Given this list of marker genes NRGN, KIAA0753, NRCAM, SERPINI1, SPP1, HOMER2, MAPT, P2RX3, here is a description of the gene set: Cluster 8: genes showing sustained pattern of down-regulation after knockdown of OPN by RNAi in the NIH3T3 cells (fibroblasts) transformed by activated HRAS. species: Mus musculus Activated forms of Ras family members are prevalent in many cancers where Ras mutants transduce signals essential for transformation, angiogenesis, invasion and metastasis. As a cancer progression model, we used NIH3T3 cells to explore the mechanism of Ras-induced tumorigenesis. Ras family mutants H-RasV12 and Rit79L strongly induced foci formation, while Rho family mutants RhoA-QL, Rac1-QL and Cdc42-QL were less effective. A comparison of downstream transcriptional targets of Ras and Rho family members using a 26 383 element cDNA microarray revealed that the osteopontin (OPN) gene exhibited the best correlation between magnitude of gene expression change and level of foci formation (r=0.96, P<0.001). In association with H-RasV12- and Rit79L-mediated transformation, foci secreted OPN protein and upregulated the OPN receptor CD44, suggesting the novel initiation of an aberrant OPN-CD44-Rac autocrine pathway. In support of this were the following observations. First, RGD-deficient OPN protein-binding activity was present in H-RasV12-transformed cells but not in control cells, and binding activity was inhibited by the CD44 blocking antibody. Second, foci formation, cell invasion and Rac activity were induced by H-RasV12 and inhibited by the CD44 blocking antibody. Third, foci formation by H-RasV12 was substantially reduced by a short interfering RNA (siRNA) specifically targeting OPN expression for knockdown. Fourth, H-RasV12-mediated transformation was not blocked by the GRGDS peptide, suggesting that OPN effects were not mediated by the integrins. Lastly, OPN knockdown affected the downstream expression of 160 '2nd tier' genes, and at least a subset of these genes appears to be involved in transformation. Indeed, four genes were selected for knockdown, each resulting in a disruption of foci formation and/or invasion. These results underscore the role of aberrant autocrine signaling and transcriptional networking during tumorigenesis. Human Gene Set: TERAMOTO_OPN_TARGETS_CLUSTER_8 from publication Teramoto H, Castellone MD, Malek RL, Letwin N, Frank B, Gutkind JS, Lee NH (PMID 15516973)